Given this list of marker genes MIR21, KIT, MIR125B1, HEY2, PDCD4, MIR100, DNMT1, NFATC3, EFEMP2, SOD2, MIR15B, MIR145, MIR1-1, GPER1, NFATC2, MIR18A, MIR140, PDGFB, MIR424, MIR221, MIR26A1, NFATC1, FGF9, ENG, CTH, here is a description of the gene set: Any process that modulates the frequency, rate or extent of vascular smooth muscle cell differentiation. Human Gene Set: GOBP_REGULATION_OF_VASCULAR_ASSOCIATED_SMOOTH_MUSCLE_CELL_DIFFERENTIATION species: Homo sapiens